The following is a description of a gene set: Cytokine-activated STAT proteins dimerize and bind to high-affinity motifs, and N-terminal domain-mediated oligomerization of dimers allows tetramer formation and binding to low-affinity tandem motifs, but the functions of dimers versus tetramers are unknown. We generated Stat5a and Stat5b double knock-in (DKI) N-domain mutant mice that form dimers but not tetramers, identified cytokine-regulated genes whose expression required STAT5 tetramers, and defined consensus motifs for dimers versus tetramers. Whereas Stat5- deficient mice exhibited perinatal lethality, DKI mice were viable, indicating that STAT5 dimers were sufficient for survival. Nevertheless, STAT5 DKI mice had fewer CD4+CD25+ T cells, NK cells, and CD8+ T cells, with impaired cytokine-induced proliferation and homeostatic proliferation of CD8+ T cells. DKI CD8+ T cell proliferation following viral infection was diminished and DKI Treg cells did not efficiently control colitis. Thus, tetramerization of STAT5 is dispensable for survival but is critical for cytokine responses and normal immune function. from publication Lin JX, Li P, Liu D, Jin HT, He J, Ata Ur Rasheed M, Rochman Y, Wang L, Cui K, Liu C, Kelsall BL, Ahmed R, Leonard WJ (PMID 22520852) species: Homo sapiens Genes up-regulated in STAT5 double knock-in T cells: control versus IL2 stimulation for 2h. Human Gene Set: GSE36888_UNTREATED_VS_IL2_TREATED_STAT5_AB_KNOCKIN_TCELL_2H_UP, and this is the list of marker genes: FIGNL1, CLEC5A, HPS5, TNIP3, AFDN, FJX1, PLPP1, HCK, TLR2, SPRED1, FTH1, CYP27B1, SPRED2, MAMLD1, MARCKSL1, SLC41A2, ARMT1, DNAJC10, PLAUR, ELOVL7, CD47, CCL20, DPP3, STEAP3, GSAP, KLHL2, WNT5A (Wnt family member 5A), FCER1G, BBIP1, SLC16A6, ATP2A2, SLC22A4, FNDC3B, FUT8, N4BP1, ASB1, LAMB3, KYNU, BMAL2, TRAF1, IL1A, STEAP1, GPR68, PRKAG2-AS2, BTG3, C15orf48, S100A12, MET, CXCL2, CCL4, PDLIM7, OLIG2, PACSIN2, WFDC21P, ALDOA, ICAM1, DDIT4, BCL6, IL6ST, ERRFI1, TMEM45B, TRAF3IP2, ITGB8, GK, TNIP1, LAMC1, HRH1, LRP12, ACKR3, HNRNPLL, IRAK2, S100A2, NRP1, NFKBIZ, ACVR1B, TREM1, VDR, KCNN4, TALDO1, SAMSN1, CKAP4, NFAT5, CXCL1, RFTN1, CXCL6, LILRA1, PLEKHA3, TNFAIP3, MFSD2A, NMRAL2P, GLIS3, EDEM2, PSMA6, S100A9, NCF2, AMPD3, MSANTD3, SH3PXD2B, ZBTB17, BTBD10, G0S2, DGKH, MIR23AHG, FPR2, TP53BP2, SOCS2, HS3ST3B1, CXCL3, FUT4 (fucosyltransferase 4, NCBI Gene Id 2526), ASPHD2, TBC1D16, DYNLT3, TNFRSF9, NFKB2, SOCS3, NETO2, CYSTM1, PLP2, PKM, ACER3, SIGLEC16, PSMA3, GPR84, TMEM115, SPECC1L (NCBI Gene Id 8221), IL1B, LDHA, SGPP2, PID1, SMURF1, STX1A, TXN, SLC7A11, SOD2, DNER (delta/notch like EGF repeat containing), HMGN2P46, CD274, LIMK2, ZC3H12A, MTF1 (metal regulatory transcription factor 1), PXK, CXCL8, NOL4L, KCNJ15, CCL2, ELL2, SURF4, DGAT2, MAML2, UHRF1, FSD1L, TBC1D30, TMEM138, NFE2L1, HIC1, PSTPIP2, CCL19, PNMA1, PPM1N, TTLL4, AZIN1, TNFAIP6, ASAP1, C3, LILRB1, CLIC1, NDP, SMPDL3A, ATP2C1, DCUN1D3 (NCBI Gene Id 123879), NEFH, TNS3, PVR, TRIM13, LINC03025, CD58, SOWAHC, PROCR, LYN, PNP, EBI3, MN1, PIK3R5, CCL7, MIR22HG, TNF, SLC39A8, CXCL5, ADM, P2RY2, TUBB, PLK3, ANKRD22, SERPINA1, FCAR, FKBP4, PTPN12, GCH1, TNFAIP8, GAPDH